The following is a description of a gene set: Human Gene Set: GSE41867_NAIVE_VS_DAY8_LCMV_EFFECTOR_CD8_TCELL_UP Genes up-regulated in CD8 T cells: naïve versus effectors at day 8. studied in species Homo sapiens During acute viral infections, naïve CD8+ T cells differentiate into effector CD8+ T cells and, after viral control, into memory CD8+ T cells. Memory CD8+ T cells are highly functional, proliferate rapidly upon reinfection and persist long-term without antigen. In contrast, during chronic infections, CD8+ T cells become “exhausted” and have poor effector function, express multiple inhibitory receptors, possess low proliferative capacity, and cannot persist without antigen. To compare the development of functional memory T cells with poorly functional exhausted T cells, we generated longitudinal transcriptional profiles for each. from publication Doering TA, Crawford A, Angelosanto JM, Paley MA, Ziegler CG, Wherry EJ (PMID 23159438), and this is the list of marker genes: FOCAD, NSMCE1, SGCB, CKAP2, SNW1, NUP133, UBR7, MYLK, EXOSC10, CCDC171, VCL, SNIP1, TCF25, ERH, RRP1B, EFCAB14, RAD51B, KDELR3, UCHL3, MIF, EFTUD2, TDP1, FILIP1, MAGED1, EXO5, COX17, HMGB1, RABGGTB, FANCB, PLAGL2, PGAM5 (NCBI Gene Id 192111), PC (NCBI Gene Id 5091), ORC1, CMC1, TRIM25, MRPL32, CAPN10, EIF2D, FBXW12, TRAPPC6A, RBM12, RIPK1, ATPAF2, EIF3D, AKIP1, UQCC6, MORF4L2, MCM8, CHPT1, RAB29, CDC16 (cell division cycle 16), NXN, LYAR, ARHGEF39, FBXO2, HDAC6, BATF3, SPEF1, POLR2G, FAM229B, PHF5A, CNOT6L, SUV39H2, PHB1, NPAT, HIVEP3, ICA1, EIF3I, IRGM, NCBP3, SLC7A6, PREP, RNASEH2C, CMSS1, KLHDC2, ATF6, PRPF31, NOL12, TROAP, IQCB1, IFRD2, RCBTB2, NIP7, LIG3, VIRMA, SENP1, TJP2, PIN1, NDUFA7, LIX1L, ZBP1, CCT5 (chaperonin containing TCP1 subunit 5), MRPL9, COX6A2, GNB1L, CMPK2, WDR76, CLPX, DHRS7, EVA1B, GPI, EMC2, UTP23, SPTSSA, CCNC, COMMD6, GLO1, NEDD8, TECR, MLF2, DUS1L, DDB1, YES1, WDR75, SNUPN, SPATA24, STX12, DDIT4, HIBCH, BTF3L4, NFIL3, TRIR, THOC7, HRAS, PSMD3, C4orf46, NDUFAF2, CENATAC, SAMHD1, ZC3HAV1, VMP1, KTN1, SDHC, UBALD2, NIF3L1, SLC25A10, DSN1, USP47, MTOR, MVD, RUVBL2, PIGT, PRLR, SNRPD1, PSME2 (proteasome activator subunit 2), UBE2T, HNRNPUL2, ATG5, TECPR2, IKBIP, STOX1, NABP1, RAB35, NDFIP1, EEF1AKMT2, POLD2, EXOC4, SELENOW, PAQR3, GFER (growth factor, augmenter of liver regeneration), ARFIP2, AMZ2, DCAF6, CUEDC2, FARP2, ZNF235, PIGY, UBE2M, EED, LATS1, INKA1, IRF4, ULBP1, MRPS16, THOP1, DOLK, TUBG1, PLOD2, MKKS, KARS1, EIF2B3, C7orf50, PPP1R10, GPHN, INTS4, LUM, GPATCH2, SUOX, HDAC3, SREK1IP1, PIERCE2, PSMD9, SIGMAR1, TOMM40, NDUFAF1, NGRN, SLC44A1, NARS1, IFT52, HTT (huntingtin)